The following is a description of a gene set: PURPOSE: Increased production of Th2 cytokines characterizes Sezary syndrome, the leukemic form of cutaneous T-cell lymphomas (CTCL). To identify the molecular background and to study whether shared by the most common CTCL subtype, mycosis fungoides, we analyzed the gene expression profiles in both subtypes. EXPERIMENTAL DESIGN: Freshly isolated cells from 30 samples, representing skin, blood, and enriched CD4(+) cell populations of mycosis fungoides and Sezary syndrome, were analyzed with Affymetrix (Santa Clara, CA) oligonucleotide microarrays, quantitative PCR, or immunohistochemistry. The gene expression profiles were combined with findings of comparative genomic hybridization of the same samples to identify chromosomal changes affecting the aberrant gene expression. RESULTS: We identified a set of Th1-specific genes to be down-regulated in Sezary syndrome as well as in a proportion of mycosis fungoides samples. In both Sezary syndrome and mycosis fungoides blood samples, the S100P and LIR9 gene expression was up-regulated. In lesional skin, IL7R and CD52 were up-regulated. Integration of comparative genomic hybridization and transcriptomic data identified chromosome arms 1q, 3p, 3q, 4q, 12q, 16p, and 16q as likely targets for new CTCL-associated gene aberrations. CONCLUSIONS: Our findings revealed several new genes involved in CTCL pathogenesis and potential therapeutic targets. Down-regulation of a set of genes involved in Th1 polarization, including the major Th1-polarizing factor, TBX21, was for the first time associated with CTCL. In addition, a plausible explanation for the proliferative response of CTCL cells to locally produced interleukin-7 was revealed. studied in species Homo sapiens from publication Hahtola S, Tuomela S, Elo L, Häkkinen T, Karenko L, Nedoszytko B, Heikkilä H, Saarialho-Kere U, Roszkiewicz J, Aittokallio T, Lahesmaa R, Ranki A (PMID 16914566) Human Gene Set: HAHTOLA_MYCOSIS_FUNGOIDES_SKIN_UP Genes up-regulated in lesional skin biopsies from mycosis fundoides patients compared to the normal skin samples., and this is the list of marker genes: SERPINF1, GPI, UBE2V1, BUD23, TRAK2, LAMP1, JAM2, IP6K2, ITGB1BP1, RPS21, JUND, NTRK2, CTSH, CCDC85B, TM4SF1, RTN3, CASK, NUDT1, TXNIP, FXR1, PDIA4, GID8, LDB2, MED13 (mediator complex subunit 13), SRRM1, SP3, SRSF3, THYN1, TOX, IGFBP3, TBC1D16 (TBC1 domain family member 16), TRIM2, IFT20, RGS5, TCF4, GSN, RPL23, MAP4K4, GNB1, SPTAN1, EIF3A, FEZ1, SLC5A3, GEMIN6, BARD1, SHOC2, GMFG, LRRC15, CALM1, FLNA, CFH, LY86, TSC22D3, CAPZB, YWHAZ, NSL1, SRSF9, FBLN1, CKLF, NUAK1, ITM2A (NCBI Gene Id 9452), BACE2, ETHE1, NFIB, STOML2, ARPC1A, CIRBP, CRBN, UBE2Z, SATB1, SSR2, ZNF22, ATG12, PDCD4, RAPGEF6, ORC5 (origin recognition complex subunit 5), SUZ12, ITPR1, UPF2, CLDN5, CCL19, SART3, REX1BD, LMCD1, SNCA, PDGFD, RCBTB2, MFAP3, FBXO11 (NCBI Gene Id 80204), MPRIP, TNPO1, NME3, DENND5A, SLA, DPP8, ARPP19, LBH, TMEM248, PWP1, SREK1, GLUD1, CTBP1, IL7R, APEX1, EIF1, SAFB, CASP1, PRKCI, HPGDS, VCAM1, CUTC (NCBI Gene Id 51076), MARCKS, RBBP4, MRTFB, TNFRSF1A, SEMA5A, NME7, CLEC4A, DAB2, CRIM1, MGAT2, SUPT16H, C6orf62, SNRNP70, SMS (spermine synthase), SAFB2, TXNDC5, SNHG32, CAPZA2, ANXA11 (NCBI Gene Id 311), ARL3, ACKR1, PPIB, ARF5, CREB3L2, SF3B1, COLEC12, GCA (NCBI Gene Id 25801), ARMCX6, KANK2, CCND2, ERH, LST1, CPA3, ITGB3BP, HNRNPU, NDUFA8, EAPP, EHD4, PFN1, CD52, FOXO3, ELAVL1, RPN1, P4HA1, YTHDF1, HLA-DQA1, ERG, LIPT1 (NCBI Gene Id 51601), DPH5, HNRNPA1, CERS2 (ceramide synthase 2), PSMB3, SNX6, MT-ND5, CNN3, TMEM14A, RBM25, SOX4, ARL6IP4, RBM15, ZNHIT3, ZNF292, C1orf115, CCNB1IP1, RECQL, PPIH